Given this list of marker genes B4GAT1, DAG1, POMGNT1, LARGE1, LARGE2, SLC35A1, FKRP, SLC35A4, FKTN, CHST10, CRPPA, RXYLT1, here is a description of the gene set: part of: DAG1 glycosylations α-Dystroglycan is a 624 aa product of the dystroglycan (DAG1) gene. As a monomer or a heterodimer with the 324 aa beta-dystroglycan it is a central component of the dystrophin-glycoprotein complex. Most of its properties like laminin binding or arenavirus receptor function are provided by matriglycan chains that are biosynthesized on threonine residues, in the mucin like domain, positions 317 455, of α-dystroglycan. Matriglycan is a glycosaminoglycan (GAG)-like polysaccharide consisting of a long linear chain of repeating heterodisaccharide and two ribitolphosphate subunits connected via the trisaccharide linker GalNAc-GlcNAc-ManP (aka Core M3) to O-threonines on α-dystroglycan. At least genes are involved in the biosynthesis of this modification, mutations of which have been shown to lead to α-dystroglycanopathies, rare illnesses ranging from mild muscular dystrophy to severe congenital syndromes that are characterized by progressive muscle weakness, brain abnormalities and seizures, as well as eye problems. studied in species Homo sapiens Reactome Pathway: Matriglycan biosynthesis on DAG1